Given this list of marker genes S100A4, MALAT1, FOS, RGS2, EGR1, MAFB (NCBI Gene Id 9935), CTSD, ERRFI1, SAA4, RGCC, DSC2, MME, CYP4B1, H2BC21, ADH1C, IFI44, GAGE12F, SPRR1B, RARRES1, SELENOP, TUT7, MMP25, PIK3C2B, RSRP1, H2AC6, ROS1, NCK1 (NCBI Gene Id 4690), DSC3, LAMB2, CAPZB, CXCL1, BTG1, GLUD1, PLEKHO2, SNCAIP, ATP1A3, ALDH6A1, ALG6, CITED2, SERPINA3, SEMA3C, CD9, IFITM2, KLRK1, DAPK1, GBP2, PLXNB1, KRT19 (keratin 19), STOM, TKT, TRIM29, FXYD3, CA2, C1S, THBS3, NFE2L2, ENG, IL1RN, TFPI, SCD, EFNA1, CDH1, CCL3, NFKBIA, LPAR6, TGFBR3 (transforming growth factor beta receptor 3), TNFAIP3, ATF3, TMEM59 (NCBI Gene Id 9528), CLU, FBXO32, F11R, EIF4B, BIRC3 (NCBI Gene Id 330), IFITM3, STAT3, CALD1, FGFBP1, NEAT1, GEM, DSP, EEF2, TACSTD2, TSC22D3, GAS1, S100A8, CYBRD1, CFB, NFIL3, RNF145, IFI16, MAP3K5 (NCBI Gene Id 4217), PNRC1, SPRR3, BCL6, SESN1, SRSF8, SCPEP1, PSAP, ACTA1, CCL21, GALNT15, MKNK2, PC, PSME1, PCDH9, IFNGR1, POLR3E, CCNG1, SAT1, IRF6, CREG1, KRT13, ANK3, DST, TP63, KLF6, FOSL2, MVP, USP15, SND1, MAOA, PTEN, AQP3, VNN1, RPLP1, TCF3, KRT14, ZBTB16, PDZK1IP1, ZNF608, CDKN1C, GADD45G (growth arrest and DNA damage inducible gamma), KYNU, ACSL1, CXCL3, KLRC3, VAV3, BNIP3L, DLG5, KRT16, TP53INP1, ANXA8L1, RPL37, INSIG1, here is a description of the gene set: from publication Sarrió D, Rodriguez-Pinilla SM, Hardisson D, Cano A, Moreno-Bueno G, Palacios J (PMID 18281472) studied in species Homo sapiens Genes down-regulated in MCF10A cells (breast cancer) grown at low (mesenchymal phenotype) compared to those grown at high (epithelial, basal-like phenotype) confluency. Human Gene Set: SARRIO_EPITHELIAL_MESENCHYMAL_TRANSITION_DN Epithelial-mesenchymal transition (EMT) is defined by the loss of epithelial characteristics and the acquisition of a mesenchymal phenotype. In carcinoma cells, EMT can be associated with increased aggressiveness, and invasive and metastatic potential. To assess the occurrence of EMT in human breast tumors, we conducted a tissue microarray-based immunohistochemical study in 479 invasive breast carcinomas and 12 carcinosarcomas using 28 different markers. Unsupervised hierarchical clustering of the tumors and statistical analysis showed that up-regulation of EMT markers (vimentin, smooth-muscle-actin, N-cadherin, and cadherin-11) and overexpression of proteins involved in extracellular matrix remodeling and invasion (SPARC, laminin, and fascin), together with reduction of characteristic epithelial markers (E-cadherin and cytokeratins), preferentially occur in breast tumors with the basal-like phenotype. Moreover, most breast carcinosarcomas also had a basal-like phenotype and showed expression of mesenchymal markers in their sarcomatous and epithelial components. To assess whether basal-like cells have intrinsic phenotypic plasticity for mesenchymal transition, we performed in vitro studies with the MCF10A cell line. In response to low cell density, MCF10A cells suffer spontaneous morphologic and phenotypic EMT-like changes, including cytoskeleton reorganization, vimentin and Slug up-regulation, cadherin switching, and diffuse cytosolic relocalization of the catenins. Moreover, these phenotypic changes are associated with modifications in the global genetic differentiation program characteristic of the EMT process. In summary, our data indicate that in breast tumors, EMT likely occurs within a specific genetic context, the basal phenotype, and suggests that this proclivity to mesenchymal transition may be related to the high aggressiveness and the characteristic metastatic spread of these tumors.